Given this list of marker genes CACNG4, CACNA2D2, CACNA1A, CACNB2, CACNA2D3 (NCBI Gene Id 55799), CACNG2, CACNA2D1, CACNB1, CACNB4, CACNA1B, CACNA1E, CACNB3 (calcium voltage-gated channel auxiliary subunit beta 3), here is a description of the gene set: studied in species Homo sapiens Reactome Pathway: Presynaptic depolarization and calcium channel opening part of: Transmission across Chemical Synapses Action potentials occur in electrically excitable cells such as neurons, muscles, and endocrine cells. They are initiated by transient opening of voltage dependent sodium channels, causing a rapid, large depolarization of membrane potentials that spread along the axon membrane.<br> The action potential travels down the axon and reaches the presynaptic terminal depolarizing the membrane in the pre synaptic terminal. The depolarization causes the voltage gated Ca2+ channels to open allowing the influx of Ca2+ that signals the release of neurotransmitter into the synaptic cleft.